Given this list of marker genes PRKCI, SLC35A4, UQCC2, SQLE, RRAGC, RPL7L1, PFDN4, FASN, MVP, STYX, SUZ12, DCTPP1, IL1R1, NME1, COMTD1, SLC7A5, PSMG1, UBQLN4, FARP2, MRPL46, SPRYD7, PBDC1, RDH11, ATP5MK, CCT7, COX19, ARL8B, METTL25, KCMF1, SOD2, TRNT1, PAM16, CLTC, GEMIN4, STAM2, EIF4G1, NUP93, PPHLN1, BZW2, OPTN, MRPL20, BTAF1, MSLN, DUS1L, MCRIP2, SUV39H2, ADAMTS5 (NCBI Gene Id 11096), CCL4, PUS7L, TMEM11, AGAP3, SLC1A5, EIF2B3, COPS8, WSB2, USP10, DOT1L, ZDHHC3, WRAP53 (WD repeat containing antisense to TP53), PPP2CA, EIF3B, TIMM8A, TRUB2, NELFE, ARV1, TUBA3C, RUVBL1, CLIC4, SKIC8, PUS1, UBE2F, AFG2A, MIEF1 (mitochondrial elongation factor 1), IFRD2, DUS4L, JRK, HEATR3, CEBPZ, NCOA5, WDFY1, CRISP3, POLR1D, LSM12, STAR, FAM98A, POGK, PRDX1, TAF1D, ESF1, RENBP, PDE8A, GRPEL1, SAR1B, PPIA, POLE3 (DNA polymerase epsilon 3, accessory subunit), CLPP, SATB1, METTL13, PVT1, APRT, NOL12, EIF5A, HMGCS1, API5, TMEM165, DNMT3B, KPNB1, SLC10A3, HINT1, CDV3, HM13, RXYLT1, HIVEP3, NAP1L4, DDX51, MTOR, DIS3, GPN1, KLHDC4, PIN1, HYAL2, RSL1D1, NFATC1, NMD3, TSEN2, PRPF4, PSMD6, PRPF3, ALG11, USP16, MED17, NUP153, DPH2, NUDCD3 (NudC domain containing 3), ZNF202, CMAS, AARS1, HMGXB3, TRIB3, DAAM1, POLR2F, PDCD5, SGPL1, TMEM51, SHQ1, CLNS1A, MFSD12 (NCBI Gene Id 60369), SRP19, SLC25A1 (NCBI Gene Id 6576), DHX15, SLC8A3, SYNGR2, DIMT1, HOMER1, SNRNP40, GFUS, MFSD1, MSANTD2, CAPRIN1, YIPF6, FUBP1, SPP1, PANK3, SUPV3L1, XPO7, MRPL16, RBBP7, KDSR, SNF8, REV1, RBM19, PUM3, NHLRC1, GNL2, SNRPA1, RTN3, RCC1, TPD52L2, BRIX1 (biogenesis of ribosomes BRX1), SLC1A4, HIC2 (NCBI Gene Id 23119), HNRNPU, UBAP2L, SEPTIN11, GLCE (glucuronic acid epimerase), TRMT61A, MIOS, TLCD2, ZNF106, CYC1, PDCD1LG2, TPD52, STK40, MAT2A (methionine adenosyltransferase 2A), SNRPD1, RHEBL1, GEMIN5, EPHA2, here is a description of the gene set: Human Gene Set: GSE22919_RESTING_VS_IL2_IL12_IL15_STIM_NK_CELL_UP Genes up-regulated in NK cells: fresh versus stimulated with IL2, IL-12 and IL15. from publication Smith MA, Maurin M, Cho HI, Becknell B, Freud AG, Yu J, Wei S, Djeu J, Celis E, Caligiuri MA, Wright KL (PMID 20944005) species: Homo sapiens We used Affymetrix expression arrays to determine changes in gene expression associated with activation of human NK cells mediated through treatment with cytokines IL-2, IL-12 and IL-18 over a 24 hour period.